The following is a description of a gene set: Marker genes curated from the annotated cluster as represented in the Descartes Human Gene Expression During Development database. Human Gene Set: DESCARTES_MAIN_FETAL_SLC26A4_PAEP_POSITIVE_CELLS species: Homo sapiens from publication Cao J, O'Day DR, Pliner HA, Kingsley PD, Deng M, Daza RM, Zager MA, Aldinger KA, Blecher-Gonen R, Zhang F, Spielmann M, Palis J, Doherty D, Steemers FJ, Glass IA, Trapnell C, Shendure J (PMID 33184181) The gene expression program underlying the specification of human cell types is of fundamental interest. The study authors generated human cell atlases of gene expression and chromatin accessibility in fetal tissues. For gene expression, the study authors applied three-level combinatorial indexing to >110 samples representing 15 organs, ultimately profiling ~4 million single cells. The study authors leveraged the literature and other atlases to identify and annotate hundreds of cell types and subtypes, both within and across tissues. Our analyses focused on organ-specific specializations of broadly distributed cell types (such as blood, endothelial, and epithelial), sites of fetal erythropoiesis (which notably included the adrenal gland), and integration with mouse developmental atlases (such as conserved specification of blood cells). These data represent a rich resource for the exploration of in vivo human gene expression in diverse tissues and cell types., and this is the list of marker genes: TVP23C, PCDHGB4, LINC02476, INVS, NUFIP1, EXOC3-AS1, FKBPL, TRMU, MED31, BTBD3-AS1, ANO7L1, LINC00862, GPRC6A, SLC4A1AP, PHB1P19 (PHB1 pseudogene 19), DEDD, PHLDA1-DT, TOR1A, MTERF2, AUNIP, SAXO1, PHKA1-AS1, EMC9, ENSG00000238142, FAM3A, RAD51D, LIG3, NOMO2, RNU6-518P, BORCS7-ASMT, SRP19, RRAGB, ZNF296, SPATA22, SELENOK, AKNAD1, VPS54, SMIM10L2A, SPAG4, NPHP4, FADD, SPATC1, FAM90A1, ZMYM1, STAG3L1, RP9P, C4orf33, CALCB, GMPPA, RXYLT1, PRPF39 (NCBI Gene Id 81951), TMEM9B-AS1, BPIFB1, PDCD6IPP2, SURF6, GPR61, TNFRSF10C, LYG1, C2CD6 (C2 calcium dependent domain containing 6), SRFBP1, ERAL1, MRPL20, UNC45A, ACTL6A, UNG, RN7SL220P, PBDC1, LINC00863, TBC1D25, LIPE-AS1, POLR3B, CACNA1D, C1orf220, TPT1P9, PUDP (NCBI Gene Id 8226), TMEM179B, CD27-AS1, ZSCAN20, NAT10, STAG3L4, RPL38P1, E2F5, AMD1P3, TYW1, ZBTB11-AS1, RPL6P27, TOMM40, SAYSD1, KNSTRN, GBE1, HECW2-AS1, NSRP1, HIBCH, MAPK10-AS1, RANBP3, SREK1IP1, RNU6-1054P, PKD2L2, SBF2-AS1, LINC02046, SATL1, NSMCE4A, TRMT10B, ZNF449, AMHR2, DHX29, LYPLAL1-DT, GPKOW, LEMD1-AS1, TMEM201, CDC123, DERL2, ATP6AP1L, ST8SIA5, CYP11B2, POLK, EME2, PSMB7, TRAPPC2L, RABEP2, LRRC14, GIN1, FRMPD3-AS1, LINC01837, ZNF683, SNORA80A, BRAT1, ASB6, ZBTB48, TOE1, CIDECP1, SLC35C2, ENTREP3, SLC25A28, STAG3L5P, FNTB, MRPS28, KDM4A-AS1, THAP10, ZNF541, MRGBP, SDHAP1, TMEM268, TMEM26, TPRA1, TUBB8B, RN7SL749P, ZPLD2P, NIFK, PVT1, ARFGAP2, PAN2, SELENOH, CCDC134, SNORD63, NUP155, LSM8, SMPD4BP, HMBOX1-IT1, ZNF747, APIP, COMT, PBX1-AS1, PTCD3, MIR4733HG, ATP9B, GPATCH1, DCTD, ZC3H12A, SPINK8, PYROXD1 (pyridine nucleotide-disulphide oxidoreductase domain 1), SYNCRIP, RPL7P9, CADM1-AS1, IL1A, BRPF3, DPH6, FAM32A, LINC02410, TENT4B, VRTN, MAD2L1, ABT1, RAD9B, ULK4P1, PWP1, ROGDI, C4orf46P2, FANCG, LINC02603, EXO5-DT, SPTLC1, PABIR3, RNU6-826P, ACADM, PRKCZ-AS1, SLC22A1, LYRM4, PCHILR, MCM8, DBTP1, CPLANE2, IRS3P, VMO1, LINC00467, LINC00887, PKD2L2-DT, CDIP1, ANKRD31, GTF2IP13, PPP1R2P4, SLC26A4, ZBTB43, DNAJC28, SURF2, LINC02296, COQ6, CCN3, TMEM86A, WDR43, CCHCR1, SKA1, ZNF211, CCDC86, LINC00290, ZNF385D-AS2, PNPLA2, SNX25P1, DNAJC6-AS1, POMK, PNMA6F (PNMA family member 6F), SDF2, SNORA14A, VAV3-AS1, JRK, IL17RC, CAGE1, PTPN23-DT, TMEM267, EPHA4, TMEM105, ZNF75D, LUCAT1, WDR5B, ITFG1-AS1, LRIG2, MAT2A, CBR1-AS1, QTRT1, DHRS1, KDM5C-IT1, SDHAF2, GPATCH2 (NCBI Gene Id 55105), LY6E-DT, EFCAB14-AS1, FBXL19-AS1, CEP55, PLXNB3-AS1, PMS2P3, TH2LCRR, BRWD1-AS1, ELAC1, RNU6-681P, USP51, PHLPP1, PLEKHA5, ZBED10P, MRPS26, ABCG1, CCT6B, MID2, FAR1-IT1, KLHDC2, SMIM10L2B-AS1, TEKT5, ZSCAN16-AS1 (NCBI Gene Id 100129195), TBCA, PDE12, ENSG00000204745, MED23, MAP3K15, BAK1, DTX3, SDHAF4, RSAD1, LTO1, REXO1, CREM, HARS2, VPS9D1-AS1, CCNL2, GTF2H3, GCNT7 (NCBI Gene Id 140687), GTF2H2B, ZNF841 (zinc finger protein 841), PHF11, KLHL11, CIBAR1 (CBY1 interacting BAR domain containing 1), TUBBP5, RNF7, ARAF, RMND1, KIRREL1-IT1, SHOC1, SIAH2, LINC00923, RN7SL574P, PHKA2-AS1, CBLN3, RMDN1, DDN-AS1, LINC01719, TLCD5, ZNF627, SCART1, RNU6-611P, PMS2P4, TMEM120A, DDX3Y, TRAF6, ATF1, LINC02745, ACVR2B-AS1, PRTFDC1, RPSAP21, ZNF845, CACNB2, SIMC1, MUC19, RNVU1-32, ENSG00000214708, AHSA2P, LINC01947, DUSP12, HROB, ZKSCAN4, BABAM2, RPL21P94, UICLM, SIMC1P1, RPS15AP3, TRIM16L, SELENOO, SMG1P1, HSD3B2, RPS29P19, PPP1R9A, KANSL1L-AS1, ACOT8, C2CD2, ZNF597